The following is a description of a gene set: studied in species Homo sapiens Diminished movement Human Gene Set: HP_DIMINISHED_MOVEMENT, and this is the list of marker genes: LAMP2, MTM1, LRRK2, MUSK, TPM2, POLG2, CHRNG, TSPOAP1, MPZ (myelin protein zero), AIFM1, PET117, MAPT, SLC25A4, DNAJC13, TOR1A, DPM2, RRM2B, NUP88, PDE8B, CLTC, EIF4G1, SLC52A2, MRPS16, PODXL, LAMA2, PAM16, CFL2, GLRA1, MYOD1, GPHN, CNTN1, VPS13C, TUBA1A, LGI3, PRKN, POLG, ATP13A2, ACTA1, CP, GFM1, GIGYF2, NR4A2, MAGEL2, DCTN1, TWNK, GBA1, DOK7, FXR1, KLHL41, ALG11, NDUFA13, KIF21A, KARS1, VPS35, ERBB3, SLC39A14, FLVCR2, SLC2A3, FRRS1L, SYNJ1, TH, DPAGT1, KLHL40, PPP2R2B, SLC18A3, CHRND, WWOX, LMOD3, PANK2, DNAJC6, NEB, SNCA (NCBI Gene Id 6622), RAPSN, TPM3 (tropomyosin 3), SLC6A3, CHRNA1, DDC (dopa decarboxylase), ATP7B, PRNP (NCBI Gene Id 96713, prion protein (Kanno blood group)), HTT, WDR45, TMEM240, FGF14 (fibroblast growth factor 14)